The following is a description of a gene set: Neighborhood of NME2 non-metastatic cells 2, protein (NM23B) expressed in in the MORF expression compendium species: Homo sapiens Human Gene Set: MORF_NME2 Neighborhood of NME2, and this is the list of marker genes: CFL1 (cofilin 1), CCT7, NEDD8, PSMD8, OAZ1, COX5B, RPS3A, RPLP0, SSNA1, HMGN2, POLR2H, NME2, RPS4X, PSMB4, MYL11, RPS7, SRP14, RPL18A, TUBA1B (NCBI Gene Id 88851), RPS14, NPM1, PABPC1, RPS6, EEF2 (NCBI Gene Id 408221), PSMC1, CYC1, RPL36AL, CLIC1, ACTG1, RPL6, RPL21, RPL27A, RALY, RPL31, RPL32, RPL34, RPL13, NME1, RPL18, RPS9, RPL24, XBP1, RPS23, NACA, COX6A1, RPS24, COX7A2L, RPL7, RPS27, DNPEP, PPIA, ELOB, RPL36A, ATP5MF, RPL8, GANAB, SAP18, EEF1D, RPL30, ATP6V1F, URM1, COX4I1, RPS29, RPL27, TSR3, ACTB, RPL23A, COX7A2, RPL38, CALM2, COX6B1, RPL13A, UQCRB, RPS12, ARF5, HINT1, PCBP2, EIF4G2, RPS20, RPS8, RPS10, BANF1, BBLN, UBE2I, CANX (NCBI Gene Id 821), JTB, STOML2, HDGF, HUWE1, UBB, RPLP2, MYL6, SSR2, RPL19, ENO1, RPL11 (NCBI Gene Id 6135), RPS5, COX7C, RPS13, NDUFA1, HSP90AA1, TMEM147, RPS11, NDUFA2, SUMO2, RAN, LYPLA2, SUMO3, EEF1A2, UBC, TBCB, RPS25, RPL15, HSPD1, RACK1, RPS3, UBA1, CALR, SNRPE, PDAP1, COX8A, PFN1, RPL9, GNAS, ATP5MJ, PUF60, RPS19 (ribosomal protein S19), SLC25A6, RPL35, FAU, MRPL23, SNRPB, ALDOA, RPL12, LDHA, ATP5F1C, PSMB1, RPL17, RPS15A (NCBI Gene Id 6210), HSP90AB1, EIF4A1, YWHAZ, PTPA, BTF3, RPS16, DRG1, HNRNPC, PGK1, AP2M1, MIF, OTUB1, SPAG7, RPS27A, EEF1G, COPS6